Given this list of marker genes Plcb3, Abhd16b, Pla2g15, Pnliprp2, Pla2g10, Gpcpd1, Gdpd1, Abhd12b, Pla2g5, Pla2g4f, Abhd12, Gdpd3, Plb1, Prdx6, Smpd4, Pnpla7, Pla2g4b, Pla2g6, Apoc1, Pla2g4c, Pnpla8, Pla2g4a, Pla2g7, Scarb1, Pla2g4e, Plcg1 (NCBI Gene Id 99130), Pla2g4d, Abhd16a, Lipc, Inpp5f, Plcb1, Ldlr, Enpp2, Prdx6b, here is a description of the gene set: The chemical reactions and pathways resulting in the breakdown of glycerophospholipids, any derivative of glycerophosphate that contains at least one O-acyl, O-alkyl, or O-alkenyl group attached to the glycerol residue. Mouse Gene Set: GOBP_GLYCEROPHOSPHOLIPID_CATABOLIC_PROCESS species: Mus musculus